The following is a description of a gene set: Genes predicted to be targets of miRBase v22 microRNA mmu_miR_7086_3p in miRDB v6.0 with MirTarget v4 prediction scores > 80 (high confidence targets). from publication Chen Y, Wang X (PMID 31504780) species: Mus musculus Mouse Gene Set: MIR_7086_3P, and this is the list of marker genes: Tpsg1, Amdhd1, Tfam, Adarb2, Nfatc3, Rad1, Mrap, Selenop